Given this list of marker genes LSM14A, MBNL1, ICOS, PROZ, L3MBTL1, C1orf50, PNPLA1, NIPBL, CLEC4D, CPS1 (carbamoyl-phosphate synthase 1), SPZ1, GLRA2, NHLRC3, CLDND1, DAB2, P3H2, KCNJ3, KAT6B, BICD1, VKORC1L1, MAPK10, OSGEPL1, DCUN1D3, MYL1, GAN, MEAK7, SV2C, IL1RAP, ZNF594, MBOAT2, OCLN, ESYT3, MDH1B, LCP2, PITPNB, TK2, GSAP, ZNF25, SLC4A5, RGS7, PM20D2, STX11, CLK4, HNRNPA2B1, MAP1B, FMO2, MYOCD, PDZD2, here is a description of the gene set: from publication Chen Y, Wang X (PMID 31504780) studied in species Homo sapiens Genes predicted to be targets of miRBase v22 microRNA hsa-miR-6855-3p in miRDB v6.0 with MirTarget v4 prediction scores > 80 (high confidence targets). Human Gene Set: MIR6855_3P